The following is a description of a gene set: Binding to acrosin, a protein that is found in the acrosomes of sperm and possesses protease and carbohydrate binding activities. Human Gene Set: GOMF_ACROSIN_BINDING studied in species Homo sapiens, and this is the list of marker genes: ZP3, ZP1, SERPINA5 (NCBI Gene Id 95024), ZP4, ZP2